Given this list of marker genes Chrna2, Chrnb1, Chrna10, Chrnd, Chrna9, Chrna5, Chrna3, Chrnb2, Chrng, Chrna1 (NCBI Gene Id 99038, cholinergic receptor nicotinic alpha 1 subunit), Chrna7, Chrne, Chrnb4, Chrna6, Chrna4, Chrnb3, here is a description of the gene set: Mouse Gene Set: GOMF_ACETYLCHOLINE_GATED_MONOATOMIC_CATION_SELECTIVE_CHANNEL_ACTIVITY Selectively enables the transmembrane transfer of a cation by a channel that opens upon binding acetylcholine. studied in species Mus musculus